Given this list of marker genes SOX4, GRAMD1B, NFX1, AHNAK2, MZB1, YPEL1, ZNF22, FLNB, PLP2, NADK, IRF4, MAP4K4, SCT, TRAF4, ARHGAP4, LILRA4, NUMA1, ST3GAL2, PHEX, PPP1R14B, DNASE1L3, ENPP2, IRF7, TBC1D8, P2RX1, CUX2, CD320, ANKRD36B, CD2AP, SEPHS1, SEPTIN11, ODC1, IRF8, MAP1A, HSP90B1, LRRC36, SCARB2, DAPK2, PFKFB2, SLC39A6, CSF2RB, ETS1, TBC1D4, RABAC1, TCF4, OFD1, LILRB4, GPR171, HHAT, DAB2, ZDHHC17, B4GALT1 (NCBI Gene Id 2683), RIPOR1, PCNT, IGF2R, NUCB2, PAIP1, NCF1C, SYNE2, SLC7A5, COMMD3, NECTIN1, SIT1, XBP1, SCAMP4, CCDC186, EPHA2, IL3RA, RUBCN, SFTPC, MAP2K6, ENTPD4, LMAN1, CMKLR1, CIRBP, COBLL1, SEL1L3, DIDO1, CTSC, APP, SCYL3, TSPAN13 (NCBI Gene Id 27075), RGS7, SERPINF1, TARBP1, MREG, TSPAN3, TCL1A, LAIR1, LTB, NRP1, RRBP1, CYFIP2 (cytoplasmic FMR1 interacting protein 2), PTGDS (prostaglandin D2 synthase), GGA2, NOTCH4, CUEDC1, MEF2D, KCNA5, POLB, PIAS3, DPPA4, ANKRD36, CTSB, HLTF, FCHSD2, CRYM, DUSP5, SCAMP5, PTPRS, AMIGO2, IGKC, USP11, NPC1, CCNYL7, SLC29A1, PLAC8, ERN1 (NCBI Gene Id 63433), TNNI2, SFT2D2, TPM2, RUBCNL, SLC7A11, LAMP1, USP24, MAGED1, ALOX5AP, CIB2, TNFRSF21, MAPKAPK2, ARF1 (NCBI Gene Id 375), RMC1, RIMS3, RNF11, ABI2, LINC00342, UBE2E3, TLR7, CCDC69, RPS6KA2, KRT5, ATP2A3, CERS6, SRP14, BLNK (NCBI Gene Id 29760), GAS6, SSR4, AEBP1, SLC20A1, AQP3, LHFPL2, EPHB1, PAFAH2, SLC7A6, EGLN3, FKBP2, ZSCAN16, RUNX2, MIA3 (MIA SH3 domain ER export factor 3), SMC6, ZHX2, SIDT1 (NCBI Gene Id 54847), CDK5R1, OGT, HMHB1 (histocompatibility minor HB-1), TRGV5, AHI1 (Abelson helper integration site 1), KCNK10, VAMP1, LAMP5, UBE2J1, ATP8A1, SPCS1, SCN9A, BSPRY, YPEL5, UGCG, CBFA2T3, BCL11A, ITM2C, SPIB, ASPH, TULP4, STMN1, UBA5, DPP4, PMS2P11, GPM6B, ADAM19, SETBP1, CAPN15, PTPRCAP, RAB15, SEC61B, DCK, MYBL2, DACH1, NPC2, here is a description of the gene set: from publication Nakaya HI, Wrammert J, Lee EK, Racioppi L, Marie-Kunze S, Haining WN, Means AR, Kasturi SP, Khan N, Li GM, McCausland M, Kanchan V, Kokko KE, Li S, Elbein R, Mehta AK, Aderem A, Subbarao K, Ahmed R, Pulendran B (PMID 21743478) Systems vaccinology has emerged as an interdisciplinary field that combines systems wide measurements and network and predictive modeling applied to vaccinology. Here we used the systems vaccinology approach to study the molecular mechanisms underlying th studied in species Homo sapiens Genes up-regulated in comparison of plasmacytoid dendritic cells (DC) versus myeloid DCs. Human Gene Set: GSE29618_PDC_VS_MDC_UP